The following is a description of a gene set: species: Homo sapiens Human Gene Set: GOBP_ADULT_FEEDING_BEHAVIOR Feeding behavior in a fully developed and mature organism., and this is the list of marker genes: BRS3, ASIP, CARTPT, GHSR, USP46, LEP, AGRP, GHRL, NPY (NCBI Gene Id 4852), DMBX1